Given this list of marker genes Mad1l1, Numa1, Cdk1, Ska3, Mad2l1bp, Kat5, Prap1, Aurkb, Ska1, here is a description of the gene set: Any process that starts or increases the frequency, rate or extent of sister chromatid segregation during mitosis. species: Mus musculus Mouse Gene Set: GOBP_POSITIVE_REGULATION_OF_MITOTIC_SISTER_CHROMATID_SEGREGATION